The following is a description of a gene set: species: Mus musculus Mouse Gene Set: GOBP_LONG_CHAIN_FATTY_ACYL_COA_BIOSYNTHETIC_PROCESS The chemical reactions and pathways resulting in the formation of a long-chain fatty-acyl-CoA any derivative of coenzyme A in which the sulfhydryl group is in a thioester linkage with a long-chain fatty-acyl group. A long-chain fatty acid has an aliphatic tail containing 13 to 22 carbons., and this is the list of marker genes: Acsl6, Elovl4, Elovl5 (ELOVL fatty acid elongase 5), Elovl7, Elovl3, Acsl4, Elovl1, Acsl5, Acsl1, Elovl6